Given this list of marker genes Prkra, Slc37a1, Lasp1 (LIM and SH3 protein 1), Stk3, Lxn, Crybg1, Arfgap3, Lgals1, Arhgap21, Pstpip2, Camkk2 (NCBI Gene Id 207565), Brdt, Trappc9, Ccnd3, Csrp1, Il7r, Mtch1, Bcl2l1, Ppp1r16b, Gsn, Ppp1r3e, Cep250, Ctdspl, Rpgrip1, Rsph1, Tspan2, Asb2, Cul7, Adam19, Pbx2, Phka1, Stx2, Nfkbie, Ano6, Ctnna1, Sh3bp1, Casp7, here is a description of the gene set: Mouse Gene Set: BOYLAN_MULTIPLE_MYELOMA_D_CLUSTER_DN from publication Boylan KL, Gosse MA, Staggs SE, Janz S, Grindle S, Kansas GS, Van Ness BG (PMID 17483317) Genes from cluster 4: down-regulated in group D of tumors arising from overexpression of BCL2L1 and MYC in plasma cells. species: Mus musculus Multiple myeloma is an incurable plasma cell malignancy for which existing animal models are limited. We have previously shown that the targeted expression of the transgenes c-Myc and Bcl-X(L) in murine plasma cells produces malignancy that displays features of human myeloma, such as localization of tumor cells to the bone marrow and lytic bone lesions. We have isolated and characterized in vitro cultures and adoptive transfers of tumors from Bcl-xl/Myc transgenic mice. Tumors have a plasmablastic morphology and variable expression of CD138, CD45, CD38, and CD19. Spectral karyotyping analysis of metaphase chromosomes from primary tumor cell cultures shows that the Bcl-xl/Myc tumors contain a variety of chromosomal abnormalities, including trisomies, translocations, and deletions. The most frequently aberrant chromosomes are 12 and 16. Three sites for recurring translocations were also identified on chromosomes 4D, 12F, and 16C. Gene expression profiling was used to identify differences in gene expression between tumor cells and normal plasma cells (NPC) and to cluster the tumors into two groups (tumor groups C and D), with distinct gene expression profiles. Four hundred and ninety-five genes were significantly different between both tumor groups and NPCs, whereas genes were uniquely different from NPCs in tumor group C and genes were uniquely different from NPCs in tumor group D. Similar to human myeloma, the cyclin D genes are differentially dysregulated in the mouse tumor groups. These data suggest the Bcl-xl/Myc tumors are similar to a subset of plasmablastic human myelomas and provide insight into the specific genes and pathways underlying the human disease.